Given this list of marker genes Fto, Pcmt1, Sdhaf1, Pgm3, Ly6a, Tubb4b, Pi4k2a, here is a description of the gene set: from publication Cui A, Huang T, Li S, Ma A, Pérez JL, Sander C, Keskin DB, Wu CJ, Fraenkel E, Hacohen N (PMID 38057668) Mouse Gene Set: CUI_PDC_IL21_RESPONSE_UP Cytokines mediate cell-cell communication in the immune system and represent important therapeutic targets. A myriad of studies have highlighted their central role in immune function, yet we lack a global view of the cellular responses of each immune cell type to each cytokine. To address this gap, the authors created the Immune Dictionary, a compendium of single-cell transcriptomic profiles of more than 17 immune cell types in response to each of 86 cytokines (>1,400 cytokine-cell type combinations) in mouse lymph nodes in vivo. A cytokine-centric view of the dictionary revealed that most cytokines induce highly cell-type-specific responses. For example, the inflammatory cytokine interleukin-1β induces distinct gene programmes in almost every cell type. A cell-type-centric view of the dictionary identified more than 66 cytokine-driven cellular polarization states across immune cell types, including previously uncharacterized states such as an interleukin-18-induced polyfunctional natural killer cell state. Genes positively differentially expressed in cell type: pDC (plasmacytoid dendritic cell) upon treatment with cytokine: IL-21 in mouse lymph nodes in vivo. species: Mus musculus